The following is a description of a gene set: species: Homo sapiens Human Gene Set: GAURNIER_PSMD4_TARGETS We previously showed that angiocidin, a tumor and vascular associated protein, is a potent inhibitor of angiogenesis and tumor growth. Angiocidin is a multidomain protein that exerts its antiangiogenic activity through multiple mechanisms, including effects on cell matrix interaction. Here, we describe another activity of angiocidin that may contribute to its antitumor activity. We show that angiocidin activates monocytes to secrete a mixture of proinflammatory cytokines and induces them to differentiate into macrophage-like cells. Using the monocytic cell line THP-1, we show that angiocidin induces the cells to become adherent and phagocytic, express macrophage markers, and secrete matrix metalloproteinase-9. Microarray analysis of control and angiocidin-treated THP-1 cells revealed that angiocidin up-regulated p105/p50, p100/p52, and rel B, components of the nuclear factor-kappaB (NF-kappaB) pathway. We confirmed the microarray data and showed that angiocidin induced phosphorylation of I kappa beta, p50, and p65 and translocation of p50 and p65 to the nucleus. We also showed that angiocidin activated up-stream mediators of NF-kappaB, such as the mitogen-activated protein kinase (MAPK) pathway and phosphoinositide-3 kinase (PI3K). Blockage of NF-kappaB and MAPK activation with small molecule inhibitors completely prevented angiocidin-mediated secretion of cytokines from THP-1 cells, but did not inhibit their adhesive phenotype. Blocking PI3K inhibited both secretion of cytokines, as well as the adhesive phenotype. These data suggest that angiocidin activates monocytes to secrete cytokines and differentiates them to a macrophage-like phenotype through at least two pathways mediated by MAPK and NF-kappaB, as well as PI3K. Inflammatory cytokines, chemokines and their cognate receptors up-regulated in THP-1 cells (monocyte) after treatment with PSMD4. from publication Gaurnier-Hausser A, Rothman VL, Dimitrov S, Tuszynski GP (PMID 18632645), and this is the list of marker genes: C2, IL10, RELB, CCR5, IL21R, CCR7, IL16, C3, C3AR1, HLA-DMB, IL1A, HLA-C, CCL18, CXCL2, TNF, CCL8, HLA-A, NFKB2, CXCL16, HLA-DRB1, IFNGR1, CXCL13, HLA-DQB1, IL12RB1, B2M, IL7, CCL2, CCL1, CXCL9, IL17RA, HLA-DRA, CCL23, IL18R1, CCL3, CCL20, IL1R2, CXCL11, HLA-DQA1, HLA-F, CXCL10, HLA-DOA, C5AR1, HLA-DRB4, IL22RA1, IL13RA1, HLA-DPB2, IL12B (NCBI Gene Id 7907), HLA-DQB2, TGFB1, HLA-E, HLA-DRB5, CCR3, CCL5, CXCL1, HLA-DPB1, TGFBR1, CCL7, CXCL6, HLA-H, CCR1, CCR10, CCL13, CCL19, HLA-B, HLA-DPA1, CXCL3, HLA-DMA, IL6, CD86, HLA-DRB3, HLA-G, NFKB1, CXCL8